Given this list of marker genes Sox9, Ets1, Ascl1, Wnt3a, Tfap2a, Hdac9 (NCBI Gene Id 79221), Ctnnb1, Tbx6, Wnt8a (wingless-type MMTV integration site family, member 8A), Axin1, Lhx2, Bmyc, Dll3, Neurog1, Dct, Dmbx1, Hdac6, Zic5, Hdac1, Col11a2, Mpz, Lhx1, Twist1, Rbpj, Myb, Tfap2b, Lhx5, Gsk3b, Mia, Hes5, Hdac5 (NCBI Gene Id 15184), Notch4, Hes1, Foxd3, Olig2, Notch3, Hdac2, Hoxa1, Prtg, Olig1, Bmp7, Hdac8, Dvl3, Isl1, Fgf8, Gjb1, Notch1, Dlx5, Cdh6, Sox10, Rhob, Olig3, Gbx2, Nfkb1, Pax3, Dvl1, Fzd3, Axin2, Hdac11, Zic1, Hdac4, Hdac7, Ctbp2, Tcf4, Fgf15, Itgb1, Mitf, Cdh2, Wnt1, Pax7, Mbp, Col2a1, Tcf7l1, Tlx2, Phox2b, Fgfr1, Fgf2, Pmp22, Fgfr3, Snai1, Id1, Msx3, Hey2, Dll4, Dll1, Smad1, Hdac10, Nfkb2, Notch2, Dvl2, Bmp4, Fgfr2, Gfap, Snai2, Hand1, Hoxb1, Sox5, Hdac3, Cdh1, here is a description of the gene set: Neural crest differentiation studied in species Mus musculus Mouse Gene Set: WP_NEURAL_CREST_DIFFERENTIATION